Given this list of marker genes Ptn, Fgf1, Med1 (mediator complex subunit 1), Rtn4, Cflar, Mdk, Xbp1, Wnt3a, Tnfaip3, Tnf, Il18, Hpn, Fgf18, Itpr1, here is a description of the gene set: Any process that activates or increases the frequency, rate or extent of hepatocyte proliferation. Mouse Gene Set: GOBP_POSITIVE_REGULATION_OF_HEPATOCYTE_PROLIFERATION studied in species Mus musculus